Given this list of marker genes FUT10, TACR2, WLS, NADK, S100A8, UNC13B, ANG, RAB33B, FOXO1, CSPG5, SCIN, CHD7, PCK2, ABCG1, CCN3, VEGFC, NPY, ADORA2A, SYBU (NCBI Gene Id 55638), GJA1, HCAR2, PRKACA, APLN, UCN3, DAB2, AGT, GATA2, BMP2, TNFSF11, SNCAIP, STXBP3, OPRM1, NEUROD1, TLR2, STC1, C1QTNF12, SYT5, CHRNA3, PFKL, GNAZ, TRPV6, CD84, PRKCA, AGTR1, MIR29B1, TM7SF3, ATG5, CASR, DTNBP1, RAB3B, ADORA2B, SCG5, DRD2, INHA, HFE, MIR199B, SAA1, FFAR1, CHMP2A, ADCYAP1, KCNB1, EDN1, RAB3D, HTR1B, VPS18, P2RX7, FBXL20, CXCL12, OTOF, ENSA, RHBDF2, OAS2, PPP3CB, CHRM3, SYTL4, STXBP2, WDR41, GATA1, FER1L5, CD177, SOX11, SOX4, CPT1A, STK39, LACRT, CREB1, NNAT, RAB9A, TPCN2, P2RY1, CYBA, RAB27B, MPC2, MLXIPL, SRI, SV2B, KMO, SYT9, CRY2, RAB21, PARD6A, MYOM1, RAB3A, CD74 (NCBI Gene Id 972), STAM, SYT3, SYT8, RAB11FIP1, SEC24A, CD160, RFX3, DRD4, IL13RA2, SPI1, ERBB3, SYT6, TCIRG1, SPX, CD200, DCANP1, BCR, NPR1, DYSF, AIMP1, HIP1R, FGFR1, CBARP (NCBI Gene Id 255057), FOXA2, RAB26, PTPRN, PPID, BAD, KCNA2, ARF6, F2R, CLASP2, BRAF, MIR766, NR1H4, GRK2, VAMP7, DYNLL1, INHBA, PPARG, DOC2B, TFF2, SIDT2, FGF20, ADRA2B, CHRNB4, GRM7, FFAR2, SELENOT, TAC1, VSNL1, SEPTIN4, JAK2, FCGR2B, G6PC2, NPY5R, IL1RAPL1, ENY2, GRM2, TNFRSF1B, C1QTNF3, SIRT4, BGLAP, RPH3A, CLOCK, PRKCE, WNK1, STXBP6, IER3IP1, SYT10, TGFB1, STXBP5, RAB11FIP5, IGF1, GCK, PAX8, CYP19A1, SLC2A2 (solute carrier family 2 member 2), TMEM132A, CHMP6, ADAM9, GHRHR, SLC30A1, LILRB1, EGF, NPSR1, SNAP25, VPS4A, MYO6, GPRC6A, EDN3, SLC6A4, LRRC8A (NCBI Gene Id 56262), SNCG, CELA2A, TUNAR, TGFB2, GDF9, C9orf72, HCRT, SNAPIN, GNAO1, TNF, SCAMP5, RIC1, GHRL, MIR30C1, CAMK2A, SLC16A1, PER2, CEACAM1, CDK5, GNAS, RUFY4, SSTR5, BMAL1, GOLPH3, F2, XBP1, KCNJ11, ECRG4, PDCD6IP, RAB11FIP3, PLA2G6, HAP1, ITSN1, RSAD2, HMGCR, KCNA5, PRKAR1A, TLR4, MYO18A, ADA, SYK, FGA, RBP4, RAB5A, CPLX4, FKBP1B, GLUD1, VAMP2, GIPR, IFNG, PRKN, GIP (gastric inhibitory polypeptide), NR1D1, SGK1, CRHR1, REST, NLGN1, SLC12A2, GPR151, RAP1BL, CLDN2 (claudin 2), GNAI2, PRAM1, NLGN2, GNA11, PDE8B, PTGER3, ITPR1, FES, SYT15, NEGR1, ADAM8, DOC2A, TFR2, REN, SYT1, CDK5R2, AP1G1, MCU, PTGES, ADIPOQ, MIR146A, KCNMB4, APBB3, MIR93, AVP, CRHBP, SYT13, CFTR, WNT7A, RAB15, TRPM5, ACSL4, PNKD, GALR1, NOTCH1, CADPS, PINK1, STX4, CLASP1, APBB1, PRKG1, NPVF, GCG, C2CD2L, EIPR1, SNF8, ABCC8, DNAJC1, MYOF, IL6, CARTPT, KCNK9, RHBDD3, SDC4, PPFIA2, NDUFAF2 (NADH:ubiquinone oxidoreductase complex assembly factor 2), NEUROG1, CCR2, KLRC2, ALOX5, UNC13D, CPLX2, F2RL2, F2RL1, SDC1, AQP1, PLCB1, P2RX1, TARDBP, MCTP1, POFUT2, ERP29, PDPK1, GJA5, PTPN23, DPH3, RAB37, NKX6-1, GPR158, IL13, SNX4 (sorting nexin 4), PLA2G4A, OSM, MICAL1, TTN, ADCY8, PHPT1, S100A10, GHSR, PICK1, RIMS1, CAPN10, ALOX12B, NMU, KCNN4, WNK4, ADRA2A, RAPGEF4, NSF, RAP1B, OSBP, MIR19A, HMGA2, DRD3, RHBDF1, SMAD4, RAB2B, IL12A, CRH, ADORA1, FGB, BMP8A, ADRA2C (NCBI Gene Id 152), RABGEF1 (RAB guanine nucleotide exchange factor 1), IRS1, SDCBP, ANXA2, ATP2A2, PLA2G1B, ADGRE2, CD33, EPHA5, TMED10, HLA-F, BMP6, MCTP2, CD2AP, PLA2G3, CYP4F2, CHRNA4, EXPH5, ACSL3, PLA2R1, NR1H3, BLK, RHBDD1, STXBP1, IL1A, PREPL, OXT, AVPR1B, MIR33A, FUT11, P3H1, IL12B, CDK16, CHGA, PASK, PRKCB, CPLX1, TGFB3, MIF, HADH, ATP9A, SLC18A3, ADORA3, RGCC, FERRY3, GAB2, RAB3GAP1, CRY1, GDNF, LIF, TIFAB, GRP, PFKFB2, CORIN, NKX3-1, HTR2A, CES1, LGI3, NOS2, RIMS2, FCER1G, SERGEF, IRS2, ITGB2, SYT17, HLA-DRB1, SERP1, SMCR8, FBXO45, EFNA5, TNFRSF11A, AVPR1A, FMR1, DVL1, ACHE, SIRT3, TSPOAP1 (TSPO associated protein 1), NHERF1, HTR2C, SPHK2, TRPM4, HTR1A, SPP1, GHRH, ANXA1, SCT, NPFF, TRH, RAB8B, MIR19B1, FRMD4A, FFAR3, MIR199A1, CADPS2, CALM3 (NCBI Gene Id 808), LRP5, CPLANE2, RIMS4, POMC, RAPGEF3, FOXL2, CD300A, RAB3C, ABCA12, FGF10, ANO1, PPP3CA, RPH3AL, NR0B2, PRKCG, GAL, TFAP2B, RAB7A, SLC25A22, PLA2G10, NCKAP1L, FAM3D, ORAI1, RASL10B, VAMP8, CPLX3, GPER1, OPRK1, RALA, KCNK16, GOLPH3L, CYP4A11, NR1H2, PPIA, ABCB11, CHMP3, LRRK2, NGF, BRSK2, LAMP1, GGCX, ISL1, ITGAM, GPLD1, IL4R (NCBI Gene Id 3566), CHRNB2, GPR68, CASK, CACNB4, TRPA1, UQCC2, HIF1A, GIT1, RAP1A, RIMS3, ARFIP1, ZBED6, ASIC1, P2RX4, SLC9B2, CHRNA6, SDHD, SYT7, BAIAP3, MEF2C, LYN, GABBR1 (gamma-aminobutyric acid type B receptor subunit 1), NPY2R, WNK3, GNAI1, SMPD3, STX1B, ABAT, UCP2, HYAL3, FGG, DNM1L, PIM3, PCLO, SYT4, ANKRD1, MIDN, TMF1, LEP, TSPO, KCNQ1 (NCBI Gene Id 3784), TREM2, PFKM, IL1B, TNFRSF1A, INS, PTPN11, RAC2, SNCA, ATP13A2, STXBP4, NF1, NLRP6, FGF23, KDM5B (NCBI Gene Id 10765), LGALS9, CD38, PRKD1, TCF7L2, STX1A, CCL5, FGR, SYN1, PRL, NPPB, MICU3, NTSR1, PDX1, SLC38A2, OXCT1, SLC4A8, PSMD9, HNF4A, SYT2, UCN, SV2C, VAMP3, GPR27, MTNR1B, RETN, APOE (apolipoprotein E), C1QTNF1, NMB, ZP3, HGS, SLC8B1, IL11, OR51E2, NEO1, BSG, MYRIP, IDH2, CCKAR, SIRT6, NRG1, VPS35 (VPS35 retromer complex component), ADTRP, MYB, ADCY5, RAC1, AACS, JAGN1, PFN2, SYT12, MYH10, RAB27A, INHBB (NCBI Gene Id 3625), CACNA1B, P2RY2, TACR1, ACVR1C, CYP51A1, VPS4B, SREBF1, TSG101, SEPTIN5, SEPTIN1, KLF7, FFAR4, SLC30A8, PPARD, FOXF1, SNX6, RAP1GDS1, RFX6, KRT20, ILDR1, PTPRN2, SYT11, here is a description of the gene set: species: Homo sapiens Any process that modulates the frequency, rate or extent of the controlled release of a substance from a cell or a tissue. Human Gene Set: GOBP_REGULATION_OF_SECRETION